Given this list of marker genes TESK1, ANLN, ROCK1, KANK2 (NCBI Gene Id 55598), DAAM2, KANK1, WDPCP, here is a description of the gene set: The orderly movement of a podocyte from one site to another, often during the development of a multicellular organism or multicellular structure. A podocyte is a specialized kidney epithelial cell. species: Homo sapiens Human Gene Set: GOBP_PODOCYTE_CELL_MIGRATION